The following is a description of a gene set: Reactome Pathway: FLT3 Signaling species: Mus musculus electronically inferred by orthology from the curated human pathway part of: Cytokine Signaling in Immune system This event has been computationally inferred from an event that has been demonstrated in another species.<p>The inference is based on the homology mapping from PANTHER. Briefly, reactions for which all involved PhysicalEntities (in input, output and catalyst) have a mapped orthologue/paralogue (for complexes at least 75% of components must have a mapping) are inferred to the other species., and this is the list of marker genes: Ubb, Sla, Socs2, Lck, Sh2b3, Syk, Cdkn1b (cyclin dependent kinase inhibitor 1B), Cbl, Rps27a, Csk, Grap2, Hras, Flt3l, Grb2